Given this list of marker genes HAS2, ANTXR2, ARAP3, ASXL1, RBMS3, EMP3, ANXA1, GNG12 (NCBI Gene Id 55970), MSN, LOXL1, DNM1, CNRIP1, SH2D5, EPB41L2, PSMB9, SPAG9, HTRA1, ACTR2, ETS1, RGS2, FBN1, AHNAK2, SNX7, NAV3, MDFIC, TWSG1, ACTG1, PTTG1, ATP10D, MCAM, PTGS2, AXL, PDE4A, DHX33, MAPRE1, BCAT1, IL15, STIL, FLI1, ANKH, GLIPR2, ASAP1, RGS4, FHOD3, WRAP53, SNAI2, SYDE1, PARVA, TFPI, SEPTIN6, CRTAP, PRKD3, SGCB, ANXA2P2, NDEL1, GLIPR1, GRK5, MIR100HG, FXYD5, NAP1L5, LDHB, CUL4B, PRKCA, MFGE8, NOL7, PFAS, COL4A2, AIDA, IGF2BP2, ASB1, SOAT1, CYP26B1, FST, ZDHHC2, P3H2, PTPRG, FZD2, PLP2, LIX1L (limb and CNS expressed 1 like), SFRP1, CENPV, SMAD9, TCEAL9, ADAMTS5, AP1S2, PAFAH1B1, PRR16, AKT3, COL6A2, RTN4, LAMB1, ANTXR1, FEZ2, CHSY1, GLS, PICALM, STK10, HEG1, TGFB2, SEMA3A, CAV2, IGFBPL1, IPO5, CEP170, FSCN1, ARHGAP23, TUBB, INPP1, WNT5B, SGK1, RALBP1, PSMD1, QKI, FLRT2, PDP1, NR2F1-AS1, ANKRD28, GSDME, NAV1, RFLNB, BAG2, MARVELD1, MMP2, ELAVL1, AKAP12, NAP1L1, RAB8B, CKAP2L, FSTL1, ILF3, TOX2, BNC2, POGLUT3, CRIM1, CFL2, C17orf49, SERPINE2, SH2B3, EFEMP2, DMD, NDC80, DSE, UBE2S, DKK3, OSMR, LAMC1, JAG1, ANKRD33B, CLIP2, GNAI1, RNF145, MAML2, SKP2, MPRIP, MTMR2, HYCC1, BIRC5, TIMP2, TEAD1, NMT2, ITSN1, GLIS3, WWTR1 (WW domain containing transcription regulator 1), CDK6, LOXL2, LBH, PTPRM, FMNL2, PROS1, CSRP2, S100A2, DZIP1, CTSC, FLNC, GALNT2, SLIT2, MTCL1, LPAR1, EDIL3, STX2, FOSL1, GPR161, HRCT1, CMTM7 (NCBI Gene Id 112616), ATM, ZYG11B, DAB2, GPRC5B, MCFD2, AAK1 (NCBI Gene Id 652453), FOXF2, UPP1, ECHDC1, SFPQ, IFNGR2, SH3KBP1, TNFRSF10D, EXTL2, TRIO, COL6A3, LTBP2, ADD3 (adducin 3), MPP1, EYA4, FOSL2, WLS, ERFE, PALM2AKAP2, SLC35B4, PXDN, SGTB, ENG, FOXC1, EXT1, UBLCP1, CAV1, DOCK10, VIM, DCBLD2, HRH1, NR3C1, KIF18B, DEPDC1, TUBB6, ABCC4, LYN, KCTD12, EVA1A, NONO, CPNE2, PSMB2, GNG11, IGF2BP3, SPDL1, NRP1, ACTN1, BIN1, NMNAT2, IL6, NUP88, HOTAIRM1, ANXA5, NT5E, GULP1 (NCBI Gene Id 51454), NCAPG, TRAM2, IRAK2, PNMA2, PLAT, PYGL, EMILIN2 (NCBI Gene Id 84034), TBC1D1, TMEM35B, CORO1C, CCDC88A, ANLN, AKR1C3, SNRPD1, LAYN, BUB1, ZEB1, TWIST2, ARHGAP21, INHBA, CDKN2C, CAVIN2, CHST2, PLAU, TRNP1, FER, PDGFC (platelet derived growth factor C), NR2F1, P3H1, GJA1, SPRY2, CAVIN1, SDCBP, EIF4A1, MET, POPDC3, BACH1, COL6A1, GPX8, GXYLT2, STRADB, TGFBR2, CDC27, CCDC82, FBLIM1, FAM20C, NOL9, MAP1B, ANXA2, PDE7B, KANK2, CASP1, PRSS12, PDGFA, KIRREL1, COL4A1, SH3GLB1, DENND5A, KATNAL1, KIF3C, DPY19L1, BICD2, GADD45A, CMTM3, TGFB1, AGPS, BCHE, LARP6, MAP4K4, TAP2, B3GNT5, SRGN, INCENP, PABPC4, TRAF3, MAP7D1, TOX, BDNF, IGFBP6, VPS54, ZCCHC24, DNAJB4, ITGAV, DPYD, WIPF1, CAVIN3, IGFBP7, ALPK2, F2RL2, CDC20, LUZP1, HACD1, NEXN, ARSJ, KLHL29, RFTN1, NAB1, NUP155, BASP1, FOXQ1, CCDC50, PTX3, C1S, WASHC4, TTL, FAM171A1, TIMP1, SLC16A7, SMAD3, ZC3H12C, MYLK, PFKP, PMP22, SPATS2L, PHLDB2, ADAMTS12, SACS, PRNP, FAM200B, SERPINE1, AKR1B1, CD99, CD44, EPHA2, EGFR, PDE3A, ELP5, ARHGEF40, FZD7, IFI16, ITPRIP, G0S2, FAS, CXCL2, COL5A1, EIF5A2, PSMB6, SPTBN1, ALKBH5, ADORA2B, EHBP1, SPARC, TGFBI, GPR176, IL11, GNG2, PIK3CD, ITM2C, PIM1, TLCD3A, MRC2, GFPT2, MXRA7, LRRK1, RGS20, CTNNAL1, TGFB1I1, PPP4R1, RAB34, CLMP, RAB31, NID2, ITPRID2, RUNX2, GSTP1, RNF182, MSRB3, ITGA1, CORO2B, NNMT, SERPINB1, ZIC2, ST3GAL6, MALT1, VCL, PAPPA, TNFAIP3, HMGA2, HJURP, PLK1, PPP1R18, CALD1, TMEM158, APCDD1L, GID4, FAT4, SV2A, CCBE1, SRPX, BICC1, BMAL2, ACTA2, ADGRE5 (NCBI Gene Id 976), STAMBPL1, FHL1, LHFPL6, SLC25A37, CHST3, ELK3 (NCBI Gene Id 2004), HSD17B11, UBE2G1, KPNB1, NECTIN3, SOCS3, AK5, MID1, CDH11, RAI14 (retinoic acid induced 14), ETV5, COL13A1, CIBAR1, TPM1, MSANTD3, IL7R, SHOX2, UBASH3B, IKBIP, DIPK1A, TMEM245, STK17A, TYMS, here is a description of the gene set: Genes down-regulated in luminal-like breast cancer cell lines compared to the mesenchymal-like ones. from publication Charafe-Jauffret E, Ginestier C, Monville F, Finetti P, Adélaïde J, Cervera N, Fekairi S, Xerri L, Jacquemier J, Birnbaum D, Bertucci F (PMID 16288205) A better molecular characterization of breast cell lines (BCL) may help discover new markers to apply to tumour samples. We performed gene and protein expression profiling of 31 BCL using whole-genome DNA microarrays and immunohistochemistry (IHC) on 'cell microarrays' (CMA), respectively. Global hierarchical clustering discriminated two groups of BCL: group I corresponded to luminal cell lines, group II to basal and mesenchymal cell lines. Correlations with centroids calculated from a published 'intrinsic 500-gene set' assigned 15 cell lines as luminal, eight as basal and four as mesenchymal. A set of genes was differentially expressed between basal and luminal samples. Mesenchymal and basal subtypes were rather similar and discriminated by only genes. The expression of 10 proteins (CAV1, CD44, EGFR, MET, ETS1, GATA3, luminal cytokeratin CK19, basal cytokeratin CK5/6, CD10, and ERM protein moesin) encoded by luminal vs basal discriminator genes confirmed the subtype classification and the validity of the identified markers. Our BCL basal/luminal signature correctly re-classified the published series of tumour samples that originally served to identify the molecular subtypes, suggesting that the identified markers should be useful for tumour classification and might represent promising targets for disease management. Human Gene Set: CHARAFE_BREAST_CANCER_LUMINAL_VS_MESENCHYMAL_DN studied in species Homo sapiens